Given this list of marker genes CCP110, RNU6-1005P (RNA, U6 small nuclear 1005, pseudogene), LINC02194, C16orf82, MIR6511A4, MIR1273H, TPRKBP2, CDR2-DT, SCNN1G, KATNIP, MIR6770-3, HS3ST2, RPL7P47, PDILT, GPR139, MFSD13B, ENSG00000260136, RN7SKP23, SMG1P1 (NCBI Gene Id 730099), LCMT1-AS2, PKD1P5, GSG1L, MIR6862-1, RRN3P3, SCNN1B, ACSM1, SMG1P4, RNU4-46P, RNU6-1340P, ABCA15P (ATP binding cassette subfamily A member 15, pseudogene), LCMT1-AS1, THUMPD1, RBBP6, ZKSCAN2-DT, CYCSP39, ABCA3P1, ACSM2A, RNU6-159P, NDUFAB1, ENSG00000261090, NPIPB3, PDZD9 (PDZ domain containing 9), RNU6-944P, IL21R, OTOAP1, MIR3680-1, COG7, RRN3P1, TMC5, ACSM5P1, ENSG00000289978, UBFD1, LINC02175, USP31, SNX29P1, HMGN2P3, CCNYL7, EEF1A1P38, LINC02890, MIR3670-3, SDR42E2, RNA5SP405, AQP8, MIR548W, GAPDHP35, ENSG00000201541, RNU6-1241P, SMG1, ERI2 (NCBI Gene Id 730570, ERI1 exoribonuclease family member 2), ENSG00000252798, ARHGAP17, SLC7A5P2, LDAF1, NPIPA9, SLC5A11, ABCC6P1, RNU6-196P, NPIPB6, TNRC6A, UQCRC2, ENSG00000260277, MOSMO, SCML2P2, CHP2, CLN3, ENSG00000286790, IQCK, TCERG1P2, EEF2K, PRKCB, XYLT1, PLA2G10IP, DNAH3, ITPRIPL2, PLK1, MIR3179-4, EARS2, HSPE1P16, ARL6IP1, ENSG00000261448, CDC37P2, GDE1, VPS35L, IL21R-AS1, EIF3CL, PALB2, LINC02129, ZKSCAN2, PKD1P4, HS3ST4, IL4R, CRYM, DCUN1D3, LINC02191, ENSG00000291179, NPIPB5, RNY1P10, VWA3A, NSMCE1, SNRPEP3, NPIPA8, ZP2, LINC01567, GGA2, NOMO2, UMOD, DCTN5, NPIPB4, LARP7P2, SBK1, ENSG00000246465, IGSF6, APOBR, GTF3C1, ACSM2B, ENSG00000260592, COQ7-DT, KNOP1, ENSG00000261195, CLEC19A, ACSM3 (acyl-CoA synthetase medium chain family member 3), NSMCE1-DT, LINC02858, NPIPB7, KDM8 (lysine demethylase 8), COQ7, REXO5, SPRING1P3, GP2, SYT17, MIR3180-3, RN7SL557P, OTOA, SMG1-DT, ANKS4B, ACSM5, LINC02195, ERN2, MIR3179-3, XPO6, MIR3670-4, POLR3E, GPRC5B, ENSG00000308301, SNORA75, ENSG00000289640, CDR2, CACNG3, METTL9, SUB1P4, TMC7, RPS15A, RNU7-24P, SMG1P3, LYRM1, LCMT1, ENSG00000308281, here is a description of the gene set: studied in species Homo sapiens Human Gene Set: chr16p12